The following is a description of a gene set: part of: Peptide ligand-binding receptors studied in species Homo sapiens Reactome Pathway: Tachykinin receptors bind tachykinins Tachykinin peptides are one of the largest family of neuropeptides, so named due to their ability to rapidly induce contraction of gut tissue. Tachykinins excite neurons, elicit behavioural responses, are potent vasodilators and contract many smooth muscles. The tachykinin family is characterized by a common C-terminal sequence, Phe-X-Gly-Leu-Met-NH2 (where X can be either an aromatic or an aliphatic amino acid) and are ten to twelve residues long.<br><br>These peptides elicit their effects via the tachykinin receptors, of which there are three types in humans (NK1,2 and 3). There are two human tachykinin peptide genes in humans, TAC1 and TAC3. TAC1 encodes substance P and substance K while TAC3 encodes neurokinin B.<br><br>Antagonists of these receptors are promising candidates for classes of antidepressants, anxiolytics and antipsychotics., and this is the list of marker genes: TACR3, TACR1, TAC3, TAC1, TACR2